Given this list of marker genes MDGA1, BBC3, H1-0, VEGFA, OAZ2, SEMA6A, MPP2, CACNB3, GPI, LRRC51, TACC2, GADD45B, CDH22, CUL7, PYCR1, HYI, SESN2, NDUFV3, PTCH1, TNFRSF19, STC2, CDKN1A, TSPAN17, P2RX3, GAMT, KLF2, ACOX2, ZCCHC24, KLHL24, IFITM2, NFKBIA, BHLHE40, ADD3, here is a description of the gene set: Human Gene Set: KASLER_HDAC7_TARGETS_2_DN from publication Kasler HG, Verdin E (PMID 17470548) Histone deacetylase 7 (HDAC7) is highly expressed in CD4(+)/CD8(+) thymocytes and functions as a signal-dependent repressor of gene transcription during T-cell development. In this study, we expressed HDAC7 mutant proteins in a T-cell line and use DNA microarrays to identify transcriptional targets of HDAC7 in T cells. The changes in gene expression levels were compared to differential gene expression profiles associated with positive and negative thymic selection. This analysis reveals that HDAC7 regulates an extensive set of genes that are differentially expressed during both positive and negative thymic selection. Many of these genes play important functional roles in thymic selection, primarily via modulating the coupling between antigen receptor engagement and downstream signaling events. Consistent with the model that HDAC7 may play an important role in both positive and negative thymic selection, the expression of distinct HDAC7 mutants or the abrogation of HDAC7 expression can either enhance or inhibit the signal-dependent differentiation of a CD4(+)/CD8(+) cell line. Genes down-regulated in DO11.10 cells (hybridoma) by expression of transciptionally activating and by transcriptionally repressive forms of HDAC7. species: Mus musculus